Given this list of marker genes DCAF15, HPSE, OLFM1, PILRA (NCBI Gene Id 29992), KCNJ9 (potassium inwardly rectifying channel subfamily J member 9), IRF9, VGLL1, BTC, SSTR2, TEP1, PISD, KLHL21, ATP8B3, IPCEF1, EVA1B (NCBI Gene Id 55194), SH3D21, APOBEC1, MME, SRPK3, GPRC5C, LRP10, MCL1, CKAP4, SMG1, POLR1G, TLR4, WDR45, CDC42EP2, TLL2 (NCBI Gene Id 7093), SYTL2 (synaptotagmin like 2), SV2C, MYF6, CASKIN2, COPA, GPR132, MYOZ3, EHD1, TAF13, RGS2, JMJD6, KLHL24, DYNC1I1, OAZ2, ADM, MLF2, NCAPH2, PTPRE, FBXO40, LRRTM4, CTSG, EMP3 (NCBI Gene Id 2014), SLC16A6, MYO1F, ETS1, HLF, DSCR4, PPP1R15A, SLC22A4, PDE4C, TNFSF14, SIPA1, TRA2A, ZNF586, TRHDE, TNFAIP3, LAMC2, GBX1, KLK11, FABP7, MTMR14 (NCBI Gene Id 64419), NEIL3, IL1A, PRKD2, PACSIN2, HAUS2, AFF2, CXCL6, B4GALNT1 (NCBI Gene Id 550623), KCTD15, MAP2K3, OSBPL2, BTG2, RAB5C, ZMAT4, FLT4, MOCS3, RASSF2, PRMT2, MAGEC2, GGNBP2, CSNK1D, KCTD20, UBE2H, FUT2, EIF4H, IL1B, IQSEC1, G0S2, ISG20, ZNF407, POF1B, PAK6, TAF4B, SLN, IFITM1, AQP8, PACRG, NR1H2, FCGR1BP, AKTIP, WASF3, PLBD1, CREB5, GPR87, USP10, TERF2IP, CDC42, SST, ZNF639, OXSR1, MUC5AC, SORL1, H3-3B, POM121, NDUFA4L2, FCN1, GRM4, DOC2B, F2RL3, IFNG, SETX, CES3, POLR2J2, PPP1R11, SF3B4, SREK1IP1, GREM2, HAL, TNFRSF9 (NCBI Gene Id 3604), DXO, ADAP1, SSX3, HYMAI, CHIC2, GPR161, ERO1B, TFG, DOCK5, HECA, CYP4F2, JARID2, CEP43, INHBB, BIN2, WDTC1, PRF1, CPPED1, CRCT1, SYNPO2L, SH3GL1, TRIM25, DAPK3, LILRA2, PAWR, TESK2, ENSG00000290731, FLOT1, OSGIN2, KCNJ2, HOXC4, RNF19B, ZNF8, CFAP46, PON1, CA1, CKB, ALDH4A1, PPFIA2, MAGEC3, BTBD2, FBXO31, BRD3, CYB5R4, RHOA, PCDHA5, FPR2, DPF3, LPAR2, CD14, PLXNB3, ALOX5, FHL5, AMDHD2, RASGRP2, ODF1, here is a description of the gene set: Human Gene Set: GSE3982_DC_VS_NEUTROPHIL_LPS_STIM_DN Genes down-regulated in comparison of dendritic cells (DC) stimulated with LPS (TLR4 agonist) at 48 h versus neutrophils stimulated with LPS (TLR4 agonist) at 1 h. In the present study we used Affymetrix oligonucleotide microarrays to produce gene transcription profiles for the major leukocyte types in humans. This comprehensive dataset enabled us to not only establish which genes were expressed in each leukocyte type, but also which genes were expressed in each subset after activation. The used of a comprehensive dataset of gene profiles from all the major human leukocyte subsets enabled a novel and powerful means for identification of genes associated with single leukocyte subsets, or different immune paradigms. species: Homo sapiens from publication Jeffrey KL, Brummer T, Rolph MS, Liu SM, Callejas NA, Grumont RJ, Gillieron C, Mackay F, Grey S, Camps M, Rommel C, Gerondakis SD, Mackay CR (PMID 16474395)